Given this list of marker genes TAF4, NUP58, GBP1, H3C4, NFATC3, DIS3, RGS2, SERPINI1, CDR2L, SOX5, ARFIP2, C4BPB (NCBI Gene Id 725), RRAD, TOP1, BCL2L11, TRIM52, ANP32E, SLC6A8, MUC7, MBD1, DNAJB9, ATP6V1C1, HERPUD1, DNAJB6, IL6, IFI6, MAP2, FKBP5, NCF2, NXT2, PRPF19, IFNA5, FOXJ1, RSRP1, PBX2, ERVW-1, PCDH9 (protocadherin 9), HIC2 (NCBI Gene Id 23119), FGFR3, POM121, CCL5, FEN1 (NCBI Gene Id 5882), GNL1, TIAL1, ZNF428, CEL, DNAJC3, LRRN3, ZNF10, ZRSR2, PTPRD, SOS1, NKX2-5, POU2F1, ATRN, MSX1, MNDA, FUBP1, CHRNA7, PIGH, SLC7A5, BRAF, CBLB, YY1, CGRRF1, TAF5L, IL24, SUSD6, FOSB, LIG4, JUNB, CREM, ITPR1, LINC02802, IL1RAP, AKAP17A, SNRK, FMOD (fibromodulin), HCP5, NXF1, TAF13, CCL8, SULT1A2 (NCBI Gene Id 6799), ZNF473, CRLF1, GBF1, EP300, CLP1, ZNF177, CDC6, GBP2, CCNE2, YKT6, RMND5A, ASCL2, PTPRE, PPP1R13B, SST, ING1, here is a description of the gene set: species: Homo sapiens The effect of human cytomegalovirus (HCMV) infection on cellular mRNA accumulation was analyzed by gene chip technology. During a 48-h time course after infection of human diploid fibroblasts, 1,425 cellular mRNAs were found to be up-regulated or down-regulated by threefold or greater in at least two consecutive time points. Several classes of genes were prominently affected, including interferon response genes, cell cycle regulators, apoptosis regulators, inflammatory pathway genes, and immune regulators. The number of mRNAs that were up-regulated or down-regulated were roughly equal over the complete time course. However, for the first 8 h after infection, the number of up-regulated mRNAs was significantly less than the number of down-regulated mRNAs. By analyzing the mRNA expression profile of cells infected in the presence of cycloheximide, it was found that a minimum of 25 mRNAs were modulated by HCMV in the absence of protein synthesis. These included mRNAs encoded by a small number of interferon-responsive genes, as well as beta interferon itself. Cellular mRNA levels in cytomegalovirus-infected cells were compared to the levels in cells infected with UV-inactivated virus. The inactivated virus caused the up-regulation of a much greater number of mRNAs, many of which encoded proteins with antiviral roles, such as interferon-responsive genes and proinflammatory cytokines. These data argue that one or more newly synthesized viral gene products block the induction of antiviral pathways that are triggered by HCMV binding and entry. Genes up-regulated in primary fibroblast cell culture after infection with HCMV (AD169 strain) at 10 h time point that were not up-regulated at the previous time point, 8 h. Human Gene Set: BROWNE_HCMV_INFECTION_10HR_UP from publication Browne EP, Wing B, Coleman D, Shenk T (PMID 11711622)